Given this list of marker genes HGSNAT, MT-ND4, FDXR, MFSD8, ELOVL4, CRX, MT-ND4L, PRPH2, MT-ND5, MFN2, RP2, TTLL5, RPGRIP1, CYP1B1, AIPL1, MT-ND1, CDHR1, GNAT2, CNGA3, DNAJC30, PDE6H, PROM1, MCAT, TLCD3B, SEMA4A, OPA1 (OPA1 mitochondrial dynamin like GTPase), RIMS1, MT-ND6, RLBP1, MT-CO1, MT-CYB, CACNA2D4, IMPG2, GUCY2D, OPN1LW, RDH5, MYOC, CFAP410, MTRFR, TIMM8A, RPGR, PITPNM3, OPN1MW, MT-CO3, NMNAT1, PDE6C, ATF6, NDUFS2, RAB28, RAX2, OPA3, POC1B, ABCA4, ADAM9, CYP4V2, EFEMP1, TMEM126A, DRAM2, MT-ND2, ITM2B, MECR, MT-ATP6, RTN4IP1, CACNA1F (calcium voltage-gated channel subunit alpha1 F), RBP3, DNM1L, CNGB3, UNC119, RHO, CFAP418, GUCA1A, SAMD7, here is a description of the gene set: Human Gene Set: HP_CENTRAL_SCOTOMA An area of depressed vision located at the point of fixation and that interferes with central vision. Central scotoma species: Homo sapiens